Given this list of marker genes ABCA1, KDM4A, APOD, TBL1X (transducin beta like 1 X-linked), MOV10, ABCG5, NR1H3, RXRA, NCOR2, TNRC6C, NCOR1, NCOA1, KDM3A, CETP, EP300, APOE, ABCG1, AGO1, ARL4C, TNRC6A, KDM1B, AGO4, HDAC3, KDM1A, AGO3, APOC2, RXRB, PLTP, GPS2, TNRC6B, NR1H2, APOC4, AGO2, APOC1, EEPD1, TBL1XR1, ABCG8, here is a description of the gene set: NR1H3 & NR1H2 regulate gene expression linked to cholesterol transport and efflux studied in species Homo sapiens Human Gene Set: REACTOME_NR1H3_NR1H2_REGULATE_GENE_EXPRESSION_LINKED_TO_CHOLESTEROL_TRANSPORT_AND_EFFLUX